Given this list of marker genes Prdm1, Notch1, Sall1, Cntrl, Dctn5, Robo1, Bmpr1a, Pitx2, Fzd2, Trip11, Pde2a, Slit2, Smad4, Acvr1, Tgfbr1, Sav1, Nfatc1, Hey1, Ltbp1, Mir92-1, Fgfrl1, Tgfbr2, Nos3, Pax8, Heg1, Bmpr2, Nsd2, Fzd1, Tgfbr3, Tgfb2, Matr3, Sufu, Mdm2, Sall4 (spalt like transcription factor 4), Bmp4, Gata3, Xirp2, Nkx2-5, Lrp2, Stra6, Hectd1, Mir20a, Ap2b1, Vangl2, Mir18, Dand5, Wnt5a, Nog, Slit3, Tbx5, Hey2, Mdm4, Sox4, Dnm2, Cplane1, Smarca4, Hes1, Prox1, Robo2, Lrp6, Sox11, Mir19b-1, Zfpm1, Frs2, Ccn1, Nprl3, Cited2, Hoxa13, Adamts19, Rbpj, Wnt11, Mir17 (microRNA 17), Smad7, Smad6, Zfpm2, Heyl, Rbm15, Lmo4, Gata4, Ptk7, Luzp1, Fgfr2, Tbx3, Gja5, Aplnr, Mir19a, Egln1, Cxcr4, Id2, here is a description of the gene set: The progression of the ventricular septum over time from its formation to the mature structure. Mouse Gene Set: GOBP_VENTRICULAR_SEPTUM_DEVELOPMENT studied in species Mus musculus